Given this list of marker genes Dhrs7, Slc4a3, Sh3d19, Asah1, Col1a2, Trp53inp2, Inpp5a, Ces2g, Atp11a, Akap12, Sptbn1, Ly6c1, Rflnb, S100a13, Il6st, Prss23, Man2b1, Col4a5, Rab11fip5, Pnp, Fkbp10, H2bc4, Ctdsp2 (CTD small phosphatase 2), Kazald1, Itgb5, Fbn1, Col4a2, Trim47, Amotl2, Dusp1, Aldh1a1, Papss2, Nrbp2, Lamb2, Id3, Vdr, Pltp, Ly6a, Vamp5, Msln (NCBI Gene Id 56047), Sri, Pstpip1, Crlf1, Ifi30, Rnpepl1, Arl2bp, Phyh, Ephx1, Tm2d2, Tspan4, Lgals9, Dipk2a, Cited2 (Cbp/p300-interacting transactivator, with Glu/Asp-rich carboxy-terminal domain, 2), Ccdc80, Nmt1, Emp2, Col5a2, Saraf, Lasp1, Fstl1, Pmp22, Tnxb, Stk10, Ctla2b, Ldaf1, Tmem45a, Sptan1, Ebf3, Adm (adrenomedullin), Sec61b, Pcolce, Aqp1 (NCBI Gene Id 11826), Per1, Hoxa2, Atf3, Fhl1, Map1lc3b (NCBI Gene Id 67443), Fzd2, Slc38a4, Plac8, Dgcr2, Smad6, Cd151, Snx10, Reck, Timp3, Ifi35, Coq9, Slpi, Sesn1 (NCBI Gene Id 68538), Rnase4, Ablim1, Dhrs3, Fos (NCBI Gene Id 14281), Ccdc6, Samhd1, Klf2, Pef1, Col5a1, Pfkp, Isg15, Grk5, Sema3c, Tubb2a, Grb10, App, Rbms2, Crtap, Llgl2, Bmp8a, Notch1, Slc29a1, Ctla2a, Slco3a1, Chfr, Mfap5, Foxp1, Gstm1, Tob1, Eno3, Jup, Gsn, Anxa8, Ndrg4, St3gal5, Copz2, Wwp2, Slc1a5, Nupr1, Shroom3, Col1a1, Tcf7l1, Lpl, Calml4, Ccn2, Ntpcr, Ddr1, Slc39a3, Guk1, Cdkl2, Cd9, Sec14l1 (SEC14-like lipid binding 1), Socs3, Eln, Gas1, here is a description of the gene set: from publication Chiaradonna F, Sacco E, Manzoni R, Giorgio M, Vanoni M, Alberghina L (PMID 16607279) Mutational activation of ras genes is required for the onset and maintenance of different malignancies. Here we show, using a combination of molecular physiology, nutritional perturbations and transcriptional profiling, that full penetrance of phenotypes related to oncogenic Ras activation, including the shift of carbon metabolism towards fermentation and upregulation of key cell cycle regulators, is dependent upon glucose availability. These responses are induced by Ras activation, being specifically reverted by downregulation of the Ras pathway obtained through the expression of a dominant-negative Ras-specific guanine nucleotide exchange protein. Our data allow to link directly to ras activation the alteration in energy metabolism of cancer cells, their fragility towards glucose shortage and ensuing apoptotic death. studied in species Mus musculus Mouse Gene Set: CHIARADONNA_NEOPLASTIC_TRANSFORMATION_KRAS_DN Genes down-regulated in transformed NIH3T3 cells (fibroblasts transformed by activated KRAS) vs normal cells.